The following is a description of a gene set: Mouse Gene Set: GOBP_ANIMAL_ORGAN_MATURATION A developmental process, independent of morphogenetic (shape) change, that is required for an animal organ to attain its fully functional state. An organ is a tissue or set of tissues that work together to perform a specific function or functions. studied in species Mus musculus, and this is the list of marker genes: Enpp1, Sema4d, Phospho1, Asxl2, Ext1, Bmp2, Ebp, Zbtb16, Mbtps2, Fat4, Adamts12, Ltf, Aldh1a2, Pth, Rhoa, Fgfr3 (fibroblast growth factor receptor 3), Gata3, Actn3, Rflnb, Ift80, Xylt1, Ccdc154, Thbs3, Lep, Pax2, Ret, Ryr1, Rflna, Adamts7, Dchs1, Grem1, Plxnb1, Igf1, Snx10, Ano6